The following is a description of a gene set: Hypernatremic dehydration studied in species Homo sapiens Human Gene Set: HP_HYPERNATREMIC_DEHYDRATION, and this is the list of marker genes: SPINK5, AQP2, KRT10, AVPR2, CA12